Given this list of marker genes LSR, KDF1, UGCG, STMN1, CLDN4, HDAC3, CLDN1, ALOX12B, FA2H, DSC1, ALOX12, CYSRT1, TP63, IL18, GRHL3, MET, GRHL1, KRT1, KRT16, FLG2, STARD7, NFKBIZ, PLEC, KPRP, SRF, TMPRSS11F, SFN, HRNR, ELOVL1, CYP26B1, KLF4, FLG, ABCA12, ALOXE3, TMEM79, ZNF750, GBA1, here is a description of the gene set: Human Gene Set: GOBP_ESTABLISHMENT_OF_SKIN_BARRIER species: Homo sapiens Establishment of the epithelial barrier, the functional barrier in the skin that limits its permeability.